Given this list of marker genes ADSL, RAN, NT5C2, EIF1AX, BLMH, MIF, PCDH1, RCC1, YWHAE, BZW1, NDUFB7, SLC25A5, GADD45A, C1QBP, MYC, NME2, IMPDH2, ANKRD6, HSP90AA1, ADK, HDDC2, APEX1, HDAC2, SHMT2, CSE1L, RPA3, PRMT1, PAICS, ATP5PF, PDXP, GART, CYP2B6, ODC1, PPP2CA, CDK4, EIF3B, MECOM, MMP12 (NCBI Gene Id 4321), PANX2, HDGF, ANGPT2, UMPS, TUBA1A (tubulin alpha 1a), ULBP2, TOP1, CTPS1, TUBA1B, MB, SUMO1, FBXO5, here is a description of the gene set: studied in species Homo sapiens Human Gene Set: MODULE_61 Genes in the cancer module 61.